The following is a description of a gene set: Any process that modulates the quantity of fibrinogen circulating in the bloodstream. Human Gene Set: GOBP_REGULATION_OF_CIRCULATING_FIBRINOGEN_LEVELS studied in species Homo sapiens, and this is the list of marker genes: B4GALT1, MIR29B1, MIR29A, MIR409, MIR29C